The following is a description of a gene set: The chemical reactions and pathways involving heme, any compound of iron complexed in a porphyrin (tetrapyrrole) ring. Mouse Gene Set: GOBP_HEME_METABOLIC_PROCESS studied in species Mus musculus, and this is the list of marker genes: Slc25a39, Slc6a9, Hebp1, Abcb7, Hmox1, Cyb5r4, Tmem14c, Ireb2, Alas2, Fxn, Ppox, Cyp2a5, Cox10, Alas1, Snx3, Alad, Bdh2, Slc48a1, Pgrmc1, Atp5if1 (ATP synthase inhibitory factor subunit 1), Fech, Cox15, Blvra, Blvrb, Srrd, Cpox, Hmbs, Slc11a2, Hmox2, Slco1a6, Abcb10, Uros, Hnf1a, Tmem14a, Urod, Abcb6, Iba57, Hpx